Given this list of marker genes Ranbp2, Lzts2, Nxf3, Eif4enif1, Alyreffm7, Mcm3ap, Rita1, Sfn, Sp100, Sarnp, Gle1, Khdrbs1, Ube2i, Cpsf6, Smurf1, Ranbp17, Eif4e (NCBI Gene Id 668879), Gsk3b, Nutf2-ps1, Sem1, Thoc7, Nsun2, Ahcyl1, Supt6, Chp1, Fmr1, Rbm15b, Nxt1, Ddx39a, Ranbp3, Rps15, Nup188, Ppm1a, Nxf2, Hhex, Gas6, Eif6, Alyreffm10, Magoh, Lsg1, Camk1, Casc3, Rbm8a, Nup155, Ncbp3, Camk4, Nup214, Alyref2, Xpo6, Dhx9, Cdkn2a, Fyttd1, Xpo7, Wnk1, Alyreffm2, Ran, Nop9, Thoc1, Eny2, Prpf4b, Malt1, Bag3, Emd, Rbm10, Park7, Rangap1, Sdad1 (NCBI Gene Id 231452), Ptpn11, Ywhae, Hdac3, Nup133, Tsc1, Xpot, Ptpn14, Ctdspl2, Npm1, Nup85 (NCBI Gene Id 445007), Nutf2, Thoc2l, Poldip3, Atxn1, Thoc5, Alyreffm4, Ddx19a, Pcid2, Ncbp2, Alyreffm6, Thoc3, Alyref, Setd2, Xpo1, Prkd1, Alyreffm14, Alyreffm11, Mdm2, Alyreffm3, Pom121l2, Hnrnpa1, Nmd3, Tpr, Frat2, Chtop, Thoc6, Desi1, Alyreffm1, Nup88, Alkbh5, Xpo5, Nol6, Nxf7, Prkaca, Wipf1, Ranbp3l (NCBI Gene Id 223332), Cdkn1b, Zc3h11a, Cdk5, Sirt6, Fam76b, Bard1, Pom121, Magohb, Pabpn1, Nup98, Nup62, Rbm33, Rapgef3, Cse1l, Tgfb1, Rasl2-9 (RAS-like, family 2, locus 9), Ddx39b, Adar, Cchcr1, Riok2, Stradb, Iws1, Egr2, Nemf, Nup153, Ifi27, Nup107, Ythdc1, Nxt2, 1700017N19Rik, Nup160, Ddx19b, Peg12, Alyreffm5, Alyreffm9 (Aly/REF export factor family member 9), Rae1, Ssb, Nup62cl, Frat1, Txn1, Pkd1, Akap8l, Eif4a3, Nutf2-ps2, Akap13, Hnrnpa2b1, Strada, Chchd4, Nrde2, Rbm22, Phax, Srsf3, Thoc2, Uhmk1, Xpo4, Mdn1 (NCBI Gene Id 78909), Nup93, Hspa9, Alyreffm8, 1700009N14Rik, Ankle1, Nxf1, Ncbp1, Ltv1, Ddx25, Sirt7, Anp32b, Calr, here is a description of the gene set: species: Mus musculus The directed movement of substances out of the nucleus. Mouse Gene Set: GOBP_NUCLEAR_EXPORT